Given this list of marker genes SHCBP1, FAM83F, PKMYT1, NME2, ATF1, SPINT2, GZMA, HSDL2, ASNS, PBDC1, MAGOH, NOP2, CKAP4, ETFB, DEK, PGR, SASS6, BLTP3B, ECH1, PTAR1, TCP1, ARHGEF37, CD300LF, PKM, TMEM165, PITPNM1, TMEM208, ARG2, FLRT2, PPP2R5A, IL36G, TATDN2, MBNL3, SLA, CENPQ, NUP107 (NCBI Gene Id 57122), ESPL1, BOLA2, NFATC2IP, CYB561A3, INHBA, MMP14 (NCBI Gene Id 4323), RAC2, ZNF207, GNAI3, RAB37, ABRACL, CALHM6, LFNG, PBX1, LY75 (lymphocyte antigen 75), EEF1E1, EVL, TKT, ACER3, DTL, KRAS, GP9, NOL12, KRTCAP2, DBF4, OGFR, SNX10, RPS6, EOMES, ALAS1, NHSL2, ASB2, CYRIB, CDC42EP2, CTTN, MLKL, SRC, CD72 (CD72 molecule, NCBI Gene Id 971), PLS1, CCNB2, STAB2, IDH3A, SDAD1, NIN, ACSL5, TINF2, PUM3 (pumilio RNA binding family member 3), DAP3, PRG3, PLTP, BRD4, POLR1E, SGO2, VCL, CCRL2, CNTD1, ANXA1, MAT2A, ITGA2B, RNPC3, TBC1D8, DOCK5, NFKBID, PSEN2, TAP2, PLSCR1, FPR1, HDDC2, FXN, SOD2, PLAUR (NCBI Gene Id 5329), PDSS1 (decaprenyl diphosphate synthase subunit 1), GNGT2, GBP4, PPP4C, MANF (NCBI Gene Id 7873), SLCO4A1, ALG5, PF4, NSUN5, GPR174, CCDC88C, ENY2, ARHGDIB, TMEM123, EXOC3L2, LGALS9B, CHIC2, THBS1, CD47, SNCA, PLCB1 (NCBI Gene Id 23236), SAMD9L, ATP5MC3, SRA1, ANGPTL3, COL4A2, CLNS1A, EIF4A3, TIAM1, VAMP5, NXPE4, JAK2, PSMB2, LCK, TMED5, MRPL33, HNRNPD, AHCY, RBBP8, ADD3, CP, GLS, FBXL14, CDCA2, ANXA11, ESAM, IRGM, BTLA, UPP1, SELPLG, CD79B, PRR5L, FASLG, MIF, ID2 (NCBI Gene Id 3398), OLFM4, CCT3, DGAT2, HLA-E (major histocompatibility complex, class I, E), RUVBL2, POM121, TIMM8A, MPC2, C1R, CHAC1, ETF1, CHST15, CKAP2, TEX30, GPR183, BTG3, CORO2A, LUC7L (NCBI Gene Id 57202), MGST2, CKS1B, TPCN2, UBE2O, NOPCHAP1, JUNB, ACTR2, LARP1, SPRY2, CD36, ASS1, TNF, ERH, RNF114, BAIAP3, TAMALIN, STAT4, NXT1 (NCBI Gene Id 29107), SLC6A4, SAMHD1, here is a description of the gene set: Genes down-regulated in bone marrow-derived macrophages with IL6 knockout and 45 min of stimulation by: LPS versus IL10 and LPS. from publication El Kasmi KC, Holst J, Coffre M, Mielke L, de Pauw A, Lhocine N, Smith AM, Rutschman R, Kaushal D, Shen Y, Suda T, Donnelly RP, Myers MG Jr, Alexander W, Vignali DA, Watowich SS, Ernst M, Hilton DJ, Murray PJ (PMID 17114459) Human Gene Set: GSE5589_LPS_VS_LPS_AND_IL10_STIM_IL6_KO_MACROPHAGE_45MIN_DN IL-10 or IL-6 stimulation of control 129xC57BL/6 murine bone marrow derived macrophages in the presence of LPS. We used microarrays to detail the global programme of gene expression changes in response to IL-6 or IL-10 stimulation in the presence of lipopolysaccharide. BMDMs were isolated from control, IL-6-/-, and IL-10-/- mice on a 129XBL/6 mixed background mice and differentiated in the presence of CSF-1 for 6-7 days. Cells were scraped and plated in 6 well plates at 2x10e6/well. Cells were washed with complete DMEM and rested for 1-2 hr before stimulation with combinations of IL-10 (10 ng/ml), IL-6 (2 ng/ml) or LPS (100 ng/ml) for 45 min or 180 mins. Complete biological replicates were performed. species: Homo sapiens